Given this list of marker genes Nupr1, Letmd1, Nudt1, Acsm5, Adss2, Ndufa5, Myh6, Gtpbp1, Rpe, Mpc1, Trim63, Pdhb (pyruvate dehydrogenase (lipoamide) beta), Ak5, Adcy10, Npr1, Gamt, Myh7, Gckr, Ldhb, Abcg3, Atp5me, Pde2a, Sult1e1, Ndufa6, Foxk1, Elovl7, Slc4a1, Fis1, Ifng, Ppara, Pcmt1, Idh1, Hspa1b (heat shock protein 1B), Pde4d, Alpi, Nme2, Trp53, Ndufs1, mt-Nd1, Mpc2, Nudt16, Fam3a, Slc25a25, Pde4a, Gpd1l, Fmo2, Mtap (methylthioadenosine phosphorylase), Fignl1, Atp5pb, Arl2, Eno3, Sult2a3, Prpsap1 (phosphoribosyl pyrophosphate synthetase-associated protein 1), Ppat, Bpgm, Prps1, Hprt1, Acp3, Tkt, Sirt6, Ppargc1a, Dlst, Stat3, Got1 (glutamic-oxaloacetic transaminase 1, soluble), G6pdx, App (amyloid beta precursor protein), Ppcdc, Nnmt, Pgls, Gucy1a1, Hk2, Ncor1, Cs, Atp5mc1, Pank3, Acsl5, Prkag2, Pde7b, Itpa, Aldoart1, Mvk, Ada, Ndufb3, Pipox, Ncf2, Sult1b1, Acnat1, Dmac2l, Nppb, Ndufs6, Eno1 (enolase 1, alpha non-neuron), Nppc, Mlxipl, Pde1a, Opa1, Sult2a8, Rora, Ak4, Adcy1, Tgfb1, Epha2, Acot5, Fitm2, Nme5, Noct, Adk (NCBI Gene Id 75969), Suclg1, Carmil1, Gmpr2, Acss2, Eno4, Hint1, Kdm1a, Ola1, Shmt1, H6pd (NCBI Gene Id 14379), Ahcyl, Gucy2f, Acnat2, mt-Nd3 (mitochondrially encoded NADH dehydrogenase 3), Bad, Galt, Acsl1, Mcee, Ndufb8 (NADH:ubiquinone oxidoreductase subunit B8), Ampd3 (adenosine monophosphate deaminase 3), Shpk, Ppp2ca, Sphk2, Slc2a9, Oas1a, Uchl1, Elovl1, Xdh, Mfsd8, Tpk1, Atp5f1e, Ndufa9, Aldoc, Slc2a6, Nme4, mt-Nd6, Atp5f1a, Slc29a1, Pals2, Pcx, Hsd17b4, Aox1, Pgk2, Acot7, Ndufs3, Hspa8, Acot12, Sdha, Eno1b, Guk1, Rab23, Nnt, Pde8b, Nudt4, Nos3 (nitric oxide synthase 3, endothelial cell), Slc25a42, Paics, Art2a, Ndufa1, Khk, Prkaca, Pgm2, Slc25a11, Vcp, Hnf4a, Acat1, Ins1, Bcl2l1, Col6a1, Pklr, Adpgk, Pde10a, Gucy2c, Acot3, Nudt3, Mvd, Fkrp, Rd3, Idh2, Suclg2, Nudt15, Cfh, Gpi1, Fbp1, Ndufa8, Flcn, Ndufs7, Abcg2, Icmt, Gimap7, mt-Atp6, Samhd1, Macroh2a1, Aldoart2, Bend3, Ndufa7, Atp5pd, Slc4a7, Pgam1, Slc22a12, Acadsb, Rhoa (ras homolog family member A), Pth2, Ces1d, Ndufab1, Parp14, Uqcc3, Nme6, Gucy2g, Jmjd8 (jumonji domain containing 8), Entpd4b, Nme3, mt-Nd5, Far1, Bloc1s6, mt-Nd4l, Pdha1, Pfkfb2, Pgd, Afmid, Slc25a12, Igf1, Papss1, Gapdhrt, Sdhc, Abcc6, Cbfa2t3, Prkag1, Atp6v1b2, Slc17a3, Pde8a, Atp5mf, Pde7a, Nmrk2, Tigar, Dip2a, Ndufb2, Gck, Slc25a51, Ptgdr, Hdac4, Mthfd2l, Glyat, Far2, Pank1, Atp2b2, Oxct2a, Lacc1, Sult2a5, Parp1, Acot1, Foxk2, Nudt10, Nudt2, Qprt (quinolinate phosphoribosyltransferase), Gmps, Ucp2, Zbtb7a, Prps1l1, Adora2b, Nt5c1b, Pgk1, Gapdhrt2 (NCBI Gene Id 434330), Trex1, Hmgcs2, Entpd7, Lipa, Bckdk, Nudt12, Mdh1, Guca1b, Naprt, Got2, Pdk4, Mtch2, Acsm3 (acyl-CoA synthetase medium-chain family member 3), Mdh1b, Adcy2, Pde4c, Ndufs2, Atp5f1c (ATP synthase F1 subunit gamma), Papss2, Gcdh, Myh3, Gnmt, Nadk2, Ndufs5, Hmgcr, Myc, Efl1, Ldha, Dgat1, Nudt8, Pfkm, Rpia, Mmaa, Dhtkd1, Tmsb4x, Elovl6, Pfkl, Adss1, Adcy6, Baat, Aco1, Pnp2, P2rx7, Gart, Nudt7, Ctns, Ndufv2, Gda, G6pc1, Acot10, Slc27a3, Hk1, Dck, Ndufb9, Atp7a, Nt5c3, Hif1a, Sult2a4, Mlycd, Ins2, mt-Nd4, Gpam, Fasn, Pid1, Ran, Hmgcl, Pnp, Dpyd, Pfas, Oard1, Gnai3, Pkm, Nampt, Acsm4, Ndufs4, Acot2, Prxl2c, Dguok, Vnn1, Mdh2, Ampd2, Nudt19, Arnt, Rbks, Csl, Macrod2, Aadat, Cox11, Slc17a1 (solute carrier family 17 (sodium phosphate), member 1), Ndufb7, Sult1c1, Ndufa10, Nme7, Acaa2, Cacnb4, Me2, Nmrk1 (NCBI Gene Id 225994), Pde5a, Pdhx, Mfn1, Prps1l3, Dlat, Gpat4, Trem2, Myog, Elovl3, Npr2, Gpd1, Oga, Ido2, Nt5c2, Ahcy, Pdk2, Parg, Sik2, Slc1a3, Dld, Pfkfb1, Ak2, Il3, mt-Atp8, Acly, Rhoq, Urah, Aprt, Eif6, Mlx, Galk1, Impdh1, Pdha2, Nudt5, Pmvk, Slc25a16, Nmnat2, Atpsckmt, Acaca, Sult2a2, Acacb, Atg5lrt, Mccc2, Lrrk2, Guca1a, Nppa, Me1, Pfkp, Ndufa12, Gucy1b1, Fhit, Atp1b1, G6pd2, Ier3, Enpp4, Ndufa2, Ido1, Gapdhs, Prkag3, Urad, Pank2, Kynu, Enpp1, Aldh1l2, Slc4a4, Pdk3, Elovl5, Ndufb6, Ndufv3, Dgat2 (diacylglycerol O-acyltransferase 2), Hkdc1, Sult2a1, Aldh1l1, Crot, Dnph1, Acss1, Ndufb5, Tspo, Atp5mc3, Spp1, Il4, Kmo, Gmpr, Hnf1a, Abcc9, Ppcs, Aldob, Ndufb1, Mpi, Sucla2, Impdh2-ps, Pde9a, Nt5c1a, Ndufa3, Mmut, Uox, Gucy2e, Gucy2d (NCBI Gene Id 434214), Nadk, Ep300, Adcy4, Ak3, Dcxr, Ndufc1 (NCBI Gene Id 66377), Aldoa, Actn3, Acsl4, Pals1, Antkmt, Acot4, Nt5c, Hmgcs1, Atp5f1d, Ncf1 (neutrophil cytosolic factor 1), Ndufb4, Esrrb, Nt5e, Aass, Mtor, Atp6-ps, Impdh2, Aspdh, Sult2b1, Stoml2, Acot8 (NCBI Gene Id 170789), Nmnat3, Vdac1, Acsl3, Dcakd, Ehhadh, Ndufv1, Sult2a6, Nmnat1, Acsl6, Ldhc, Myh8, Prkn, Map2k1, Prkaa1, Gale (galactose-4-epimerase, UDP), Ndufs8, Adal, Zbtb20, Coasy, Eno2, Atp6v1b1 (NCBI Gene Id 269766), Slc37a2, Ttr, Adsl, mt-Nd2, Atp1a2, Slc25a13, Tkfc, Prkaa2 (protein kinase, AMP-activated, alpha 2 catalytic subunit), Adcy8, Art2b, Atp5f1b, Pfkfb3, Adcy9 (adenylate cyclase 9), Macrod1, Rptor, Acot11, Mthfd1, Nme1, Ndufb11, Entpd1, Pdk1, Ogt, Ndufc2, Dnm1l, Nudt9, Adcy3, Pgam2, Psen1, Nudt11, Atic, Ampd1, Slc16a9, Nadsyn1 (NCBI Gene Id 78914), Hrh3, Prpsap2, Ndufa13, Bcl2l13, Ldhd, Tpi1, Oxsm, Ndufa11, Pank4, Gpd2, Sarm1, Sult2a7, Snca, Gapdh, Haao, Tdo2, Cyb5r4, Elovl4, Prps2, Git1, Ndufb10, Nudt17, Nudt13, Oasl2, Ddit4, Slc25a22, Htr2a, Atp6v1a, Enpp3, Selenon, Atp5mg, Hk3, Abcd1, Ogdh, Adcy5, Them5, Kat2b, Atp5mc2, Insr, Acot9, Slc25a18, Src, Atp5pf, Acsm2, Clpx, Dnajc30, Hsd11b1, Sdhd, Ak1 (NCBI Gene Id 59018), Adcy7, Atp5if1, Entpd4, Pemt, Mlst8, Taldo1, Atp5po, Acsm1, Nudt18, Sdhb, Acot6, here is a description of the gene set: The chemical reactions and pathways involving a purine-containing compound, i.e. any compound that contains purine or a formal derivative thereof. studied in species Mus musculus Mouse Gene Set: GOBP_PURINE_CONTAINING_COMPOUND_METABOLIC_PROCESS